Given this list of marker genes IL1A, HARS1, MICA, IL5, HLA-DOA, IL2RA, C4B, PECR, IL22, HLA-B, FOXP3, TNF (NCBI Gene Id 7124), GDNF, IL4, CD80, C7, CCL21, CTLA4, IL1B, COL5A1, GNLY, HLA-DOB, HLA-DPA1, HLA-C, CD40, FASLG, HLA-DMB, C4A, HLA-DQB1, GZMB, C5, STAT1, HLA-DRB5, HLA-G, C6, GABPA, CXCL11, PRKCZ, IL12B, AGTR1, CXCL13, TUBA1B, IL12A (interleukin 12A), CD86, HLA-F, C3, IL17A, HLA-DQA1, IFNG, CSNK2A2, IL13, C8A, FAS, TGFB1, HLA-E, CD55, HLA-DRA, CASP3, LRRK2, CXCL9, HLA-DRB1, CXCL8, HLA-DMA, ABCB1, IL10, CXCL12, IL2, C1QB, CXCR5, CASP7, C2, HLA-DQA2 (major histocompatibility complex, class II, DQ alpha 2), CASP8, CASP9, CD28, PRF1, VIM, HLA-DPB1, VEGFA, C1QA, BHMT2, CCL19, CD40LG (CD40 ligand), IL21, PDGFRA, HLA-A, C1QC, C9, C8B, here is a description of the gene set: Human Gene Set: WP_ALLOGRAFT_REJECTION species: Homo sapiens Allograft rejection